Given this list of marker genes UBC, SOCS6, SH2B3, UBA52, RPS27A, FLT3LG, CBL, SLA2, UBB, SLA, CSK, SOCS2, ABL2, PTPRJ, FLT3, here is a description of the gene set: species: Homo sapiens Reactome Pathway: Negative regulation of FLT3 FLT3 activity is negatively regulated through several mechanisms including dephosphorylation, interaction with protein partners that limit downstream signaling pathways, and by ubiquitin-mediated internalization and degradation. part of: FLT3 Signaling